Given this list of marker genes MECP2, DGKQ, APOA1, REST, BMP5, DKK3, CBR1, CACNA1H, CRH, CYP21A2, BMP2, CYP17A1, H6PD, STUB1, SERPINA6, WNT4, YWHAH, ATP1A1, CYP11B1, CYP11B2, NR3C1, NR5A2, STAR, GAL, CYP11A1, HSD11B2, here is a description of the gene set: studied in species Homo sapiens The chemical reactions and pathways involving glucocorticoids, hormonal C21 corticosteroids synthesized from cholesterol. Glucocorticoids act primarily on carbohydrate and protein metabolism, and have anti-inflammatory effects. Human Gene Set: GOBP_GLUCOCORTICOID_METABOLIC_PROCESS